The following is a description of a gene set: species: Homo sapiens The end of a filopodium distal to the body of the cell. Human Gene Set: GOCC_FILOPODIUM_TIP, and this is the list of marker genes: MYO10, OSBPL3, ABI2, FZD3, CIB1, MYO5A, FMR1, TTYH1, MORN4, MYO3A, ABITRAM, ABI1, NLGN1, AP2A1, MYO3B, VIL1, EPHB1, UBE2K